The following is a description of a gene set: Catalysis of the transfer of an alkyl or aryl (but not methyl) group from one compound (donor) to another (acceptor). species: Homo sapiens Human Gene Set: GOMF_TRANSFERASE_ACTIVITY_TRANSFERRING_ALKYL_OR_ARYL_OTHER_THAN_METHYL_GROUPS, and this is the list of marker genes: MAT1A, FNTA, GSTM1, GGPS1, GSTT2B, GSTO1, DTWD1, MGST2, DPH2, LTC4S, RABGGTB, RABGGTA, MMAB (metabolism of cobalamin associated B), DHDDS, GSTM2, TRMT12, UBIAD1, DPH1, GSTZ1, MGST3, NANS, GSTA3, MAT2B, FDFT1, CHM, PTAR1, AGPS, GSTO2, LANCL1, MGST1, CLIC2, TSR3, GSTT4, GSTM4, PTGES, GSTA2, PDSS2 (decaprenyl diphosphate synthase subunit 2), HPGDS, GSTM5, ALOX5AP, MAT2A, NUS1, FDPS, GSTT2, SH3BGRL3, GSTT1, DHPS, GSTA1, MMACHC, SMS, COX10, TRIT1, COQ2 (coenzyme Q2, polyprenyltransferase), GSTA4, SRM, GSTM3, GSTK1, FNTB, PDSS1, GSTA5, DTWD2, PGGT1B, GSTP1 (glutathione S-transferase pi 1), HMBS